Given this list of marker genes Iyd, Asmt, Th, Dbh, Dio3, Tpo, Duox1, Aanat, Duox2, Ddc, Pnmt, Tph1, Tph2, Cga, Dio1, Slc5a5, Tshb, here is a description of the gene set: studied in species Mus musculus Mouse Gene Set: REACTOME_METABOLISM_OF_AMINE_DERIVED_HORMONES Metabolism of amine-derived hormones